Given this list of marker genes ARMCX6, COLEC12, PFN2, PMP22, TPM1, DGKZ, CELSR2, SRPX, H2AC8, SERPINA1, CTSA, SPRY4, NHERF1, NDST4, ARMCX3, ALDH3B1, MSN, PRODH, RAPGEFL1, SPINK4 (serine peptidase inhibitor Kazal type 4), IGFBP3, FGFR4, GATA4, H4C12, HGD, KCNMA1, SLC16A2, RET, FGR, LRP4 (NCBI Gene Id 4038), ARMCX2, WNT4, CHST8, CTSD, KRT13, PTGES, SEC61A1, ST3GAL5, TMEM45A, CACNA1I, TNIK, OGFRL1, ARHGAP26, H1-2, GPC4, ETFB, PTP4A1, BAG1, ASB13, ESRRG, ENSG00000248161, LRRC15 (leucine rich repeat containing 15), SLCO2A1, C4A, FASN, TGFBR3, WDR45B, CITED1, LAMA4, MGST3, GP2, STARD8, RGS3, ADCY1, GALNT6, HMGCS2, SLC27A2, AMBP, here is a description of the gene set: Genes up-regulated SUM44/LCCTam cells (breast cancer) resistant to 4-hydroxytamoxifen relative to the parental SUM44 cells sensitive to the drug. One-third of all estrogen receptor (ER)-positive breast tumors treated with endocrine therapy fail to respond, and the remainder is likely to relapse in the future. Almost all data on endocrine resistance has been obtained in models of invasive ductal carcinoma (IDC). However, invasive lobular carcinomas (ILC) comprise up to 15% of newly diagnosed invasive breast cancers each year and, whereas the incidence of IDC has remained relatively constant during the last 20 years, the prevalence of ILC continues to increase among postmenopausal women. We report a new model of Tamoxifen (TAM)-resistant invasive lobular breast carcinoma cells that provides novel insights into the molecular mechanisms of endocrine resistance. SUM44 cells express ER and are sensitive to the growth inhibitory effects of antiestrogens. Selection for resistance to 4-hydroxytamoxifen led to the development of the SUM44/LCCTam cell line, which exhibits decreased expression of ERalpha and increased expression of the estrogen-related receptor gamma (ERRgamma). Knockdown of ERRgamma in SUM44/LCCTam cells by siRNA restores TAM sensitivity, and overexpression of ERRgamma blocks the growth-inhibitory effects of TAM in SUM44 and MDA-MB-134 VI lobular breast cancer cells. ERRgamma-driven transcription is also increased in SUM44/LCCTam, and inhibition of activator protein 1 (AP1) can restore or enhance TAM sensitivity. These data support a role for ERRgamma/AP1 signaling in the development of TAM resistance and suggest that expression of ERRgamma may be a marker of poor TAM response. studied in species Homo sapiens from publication Riggins RB, Lan JP, Zhu Y, Klimach U, Zwart A, Cavalli LR, Haddad BR, Chen L, Gong T, Xuan J, Ethier SP, Clarke R (PMID 18974135) Human Gene Set: RIGGINS_TAMOXIFEN_RESISTANCE_UP